Given this list of marker genes Kctd13, Mkks, Tmeff2, Pfn1, Inpp5k, Wnt11, Smad3, Limch1, Abl1, Arhgef18, Fam171a1, Sdc4, Ppp1r9a, Kank3, Was, Arhgef5, Arhgef10l, Limk1, Asap3, Srf, Arhgap6, Phactr1, Phldb2, Sh3pxd2b, Gpr65, Dlc1, Serpinf2, Fermt2, Synpo, Carmil1, Tacr1, Prkcq, Clasp1, Cgnl1, Zyx, Tacstd2, Tac1, Pfn2, Rock2, Pdlim1, 4930544G11Rik, Tgfb3, Tnfaip1, Itgb1bp1, S1pr1, Rapgef3, Rhoa, Sorbs3, Tmsb15b2, Myoc, Apoa1, F11r, Itgb1, Pik3r1, Arap1, Fhdc1, Ttc8, Cul3, Ppm1f, Luzp1, Fhod1, Clasp2, Pak2, Ptger4, Tmsb15l, Mtor, Pak1, Actg1, Met, Tpm1, Coro2b, Rgcc, Bbs4, Epha1 (Eph receptor A1), Wnt4, Rhpn2, Wasf2, Tjp1, Pdlim4, Kiss1r, Kank4, Frmd7, Alms1, Itgb5, Eln, Ccn2, Arrb1, Tesk1, Src, Lpar1, Ppm1e, Kank2, Rhoc, Ppfia1, Arhgap28, Myl9, Rhpn1, Zeb2, Rac1, S100a10, Cd47, Spag6l, Pxn, Tsc1, Dnm2, Arhgef15, Sorbs1, Ptk2b, Evl, Arhgef10, Bag4, Cdc42, Ccdc88a, Synpo2l, Nrp1, Braf, Pik3r2, Stmn1, Nf2, Nox4, Tgfbr1, here is a description of the gene set: The aggregation, arrangement and bonding together of a set of components to form a stress fiber. A stress fiber is a contractile actin filament bundle that consists of short actin filaments with alternating polarity. species: Mus musculus Mouse Gene Set: GOBP_STRESS_FIBER_ASSEMBLY